The following is a description of a gene set: Background: The existence of a radiation bystander effect, in which non-irradiated cells respond to signals from irradiated cells, is now well established. It raises concerns for the interpretation of risks arising from exposure to low doses of ionizing radiation. However, the regulatory mechanisms involved in the bystander response have not been well elucidated. To provide insight into the signaling pathways responding in bystanders, we have measured global gene expression four hours after bystander and direct alpha particle exposure of primary human lung fibroblasts. Results: Although common p53-regulated radiation response genes like CDKN1A were expressed at elevated levels in the directly exposed cultures, they showed little or no change in the bystanders. In contrast, genes regulated by NF_B, such as PTGS2 (cyclooxygenase-2), IL8 and BCL2A1, responded nearly identically in bystander and irradiated cells. This trend was substantiated by gene ontology and pathway analyses of the microarray data, which suggest that bystander cells mount a full NF_B response, but a muted or partial p53 response. In time-course analyses, quantitative real-time PCR measurements of CDKN1A showed the expected 4-hour peak of expression in irradiated but not bystander cells. In contrast, PTGS2, IL8 and BCL2A1 responded with two waves of expression in both bystander and directly irradiated cells, one peaking at half an hour and the other between four and six hours after irradiation. Conclusion: Two major transcriptional hubs that regulate the direct response to ionizing radiation are also implicated in regulation of the bystander response, but to dramatically different degrees. While activation of the p53 response pathway is minimal in bystander cells, the NF_B response is virtually identical in irradiated and bystander cells. This alteration in the balance of signaling is likely to lead to different outcomes in irradiated cells and their bystanders, perhaps leading to greater survival of bystanders and increased risk from any long-term damage they have sustained. species: Homo sapiens from publication Ghandhi SA, Yaghoubian B, Amundson SA (PMID 19108712) Human Gene Set: GHANDHI_DIRECT_IRRADIATION_DN Genes significantly (FDR < 10%) down-regulated in IMR-90 cells (fibroblast) in response to direct irradiation., and this is the list of marker genes: PER1, G6PD, ARHGEF37, MRPS6, PTK7, RGMA, NFE2, S1PR1, PRDM6 (NCBI Gene Id 93166), KCNK3, IRF1, SEMA4D, DEPP1, OPRL1, CCDC85C, CNKSR3, MN1, BCL11A, S100P, SYBU, FZD4, PLEKHA6, ELANE, PBX2 (PBX homeobox 2), OLFML2B, HOXB3, EVI5L, ARHGEF25, MDFI, BRINP3, TOX, NR3C2, VSTM2L, FAM50B, MIDN